The following is a description of a gene set: Genes predicted to be targets of miRBase v22 microRNA hsa-miR-4794 in miRDB v6.0 with MirTarget v4 prediction scores > 80 (high confidence targets). Human Gene Set: MIR4794 from publication Chen Y, Wang X (PMID 31504780) studied in species Homo sapiens, and this is the list of marker genes: LRCH1, BAIAP2L1, FAT1, NTRK2, SMAP1, RSBN1L, DNASE2, AFG2B, DHODH, C15orf40, NR4A3, SORD, HDHD2, RHOBTB3, LPP, ZNF74, TBC1D2B, GRAMD1B, TMEM135, TMEM108, TRAF3IP2, AAK1, AREL1, SYNE2, ZFAND3, KCNN3, PHLDB1, SPRR2E, ATP2A2, SLC2A4, REPS2, PHACTR4, SLC7A14, SORT1, RALB, ZNF776, PDE1B, HMGCR, MAPK8, TMEM38A, ENTPD1, WDR1, DCAF11, SEC23A, GGCX, HIPK1, CDC42SE1, SLC19A2, TMEM245, GALNTL6, SCAF11, JPT1, CDC27, TCEANC2, TPD52L1 (NCBI Gene Id 7164), FAM199X, BCL9L (NCBI Gene Id 283149), LRATD1, CBX5, CUL3, CRACD, CYP20A1, ZBTB4 (NCBI Gene Id 57659), ATP1B4, CAMK2G, TCEAL8, CNTNAP4, TCEAL7, LRRC7, PPARD, SEPTIN7, SLC16A10, EFHD1 (EF-hand domain family member D1), KDR, PSME3IP1, PANK3, FBXO17, SYT1, SRGAP2, BTAF1, ELP5, GRIK2 (glutamate ionotropic receptor kainate type subunit 2), MTHFSD, ZNF37A, MAPK6, APPL2, NETO1, ARHGAP21, PSAP, DDX3Y, ATP10B, FAM193A, PRKG1, ZNF544, CACHD1, WIPF3, DDX3X, TNFRSF25, ZNF629, YARS2, HMOX2